The following is a description of a gene set: studied in species Mus musculus Enables the transfer of a polyol from one side of a membrane to the other. A polyol is any polyhydric alcohol. Mouse Gene Set: GOMF_POLYOL_TRANSMEMBRANE_TRANSPORTER_ACTIVITY, and this is the list of marker genes: Aqp9, Slc5a11, Aqp7, Slc2a13, Aqp11, Aqp1, Aqp2, Aqp3, Slc5a3